Given this list of marker genes Tmem107, Cc2d2b, Spata7 (spermatogenesis associated 7), Nphp4, Tctn1, Tctn2, Cc2d2a, Cplane1, Mapk15, here is a description of the gene set: A process in which a protein is transported to, or maintained in, a location within a ciliary transition zone. Mouse Gene Set: GOBP_PROTEIN_LOCALIZATION_TO_CILIARY_TRANSITION_ZONE species: Mus musculus